Given this list of marker genes UNC5C, ACVR1B, DEFB1, LHFPL2, VEGFA, TACR2, EDNRB, IRGC, CIB1, INSR, TAC4, UBE2B, DHX37, PIWIL2, PRSS37, IQCF1, CCR6, ADAM7, TACR1, YTHDC2, PRDM9, PDE3A, PLB1, AURKA, OOEP, INHBA, DMRT1, SMURF2, SOX9, CTNNB1, SRY, DAZL, SHH, STRA8, CCDC87, APELA, CFAP69, WT1, RAD51AP1, P2RY1, NPR2, CACNA1H, RNASE10 (ribonuclease A family member 10 (inactive)), ZFPM2, MAPK15, PLCB1, WNT4, CITED2, SYDE1, TAC1, MSX1, FAM170B, MSX2, OVOL1, NPM2, RETN, CDC25B, MEIOC, NR5A1, BNC1, OXT, LFNG, CDC25A, GLRA1, C1QBP, TACR3, HYAL3, PGAM4, ANKRD31, TAC3, TMPRSS12, AR, SIRT2, PLA2G10, AGO2, RBM46, CDC25C, SYCE3, ZP4, ZP3, MEIOSIN, HDAC2, WNT5A, KNL1, BAX, PRDM14, INHBB, ABCB1, here is a description of the gene set: Human Gene Set: GOBP_POSITIVE_REGULATION_OF_REPRODUCTIVE_PROCESS Any process that activates or increases the frequency, rate or extent of reproductive process. species: Homo sapiens